The following is a description of a gene set: species: Homo sapiens Any process that activates or increases the frequency, rate or extent of blood circulation. Human Gene Set: GOBP_POSITIVE_REGULATION_OF_BLOOD_CIRCULATION, and this is the list of marker genes: TGFB2, ATP1A2, SLC1A1, KCNQ1, ATP1A1 (ATPase Na+/K+ transporting subunit alpha 1), NKX2-5, PTPN1, PDE4D, RGS4, GCH1, UCN, ADM5, MIR1-1, RYR2, ADM, ADRB1, ATP2A2, ADA, GHRL, NPPA, APELA, TACR3, GSK3A, HSP90AA1, ACE2, EDN1, TRPM4, ADM2, AVPR1A, RGS2, EDN3, TPM1, ADRA1A, CHGA, HRC, APLN, SCN3B, NMU, EDN2, HEY2